Given this list of marker genes Zic1, Msx1, Pax6, Dcx, Tubb3, here is a description of the gene set: from publication Tesar PJ, Chenoweth JG, Brook FA, Davies TJ, Evans EP, Mack DL, Gardner RL, McKay RD (PMID 17597760) species: Mus musculus Mouse Gene Set: TESAR_ALK_AND_JAK_TARGETS_MOUSE_ES_D4_UP The application of human embryonic stem (ES) cells in medicine and biology has an inherent reliance on understanding the starting cell population. Human ES cells differ from mouse ES cells and the specific embryonic origin of both cell types is unclear. Previous work suggested that mouse ES cells could only be obtained from the embryo before implantation in the uterus. Here we show that cell lines can be derived from the epiblast, a tissue of the post-implantation embryo that generates the embryo proper. These cells, which we refer to as EpiSCs (post-implantation epiblast-derived stem cells), express transcription factors known to regulate pluripotency, maintain their genomic integrity, and robustly differentiate into the major somatic cell types as well as primordial germ cells. The EpiSC lines are distinct from mouse ES cells in their epigenetic state and the signals controlling their differentiation. Furthermore, EpiSC and human ES cells share patterns of gene expression and signalling responses that normally function in the epiblast. These results show that epiblast cells can be maintained as stable cell lines and interrogated to understand how pluripotent cells generate distinct fates during early development. Genes up-regulated in mES cells (mouse embryonic stem cells) after tratment with the ALK inhibitor SB-431542 and JAK inhibitor I.